Given this list of marker genes Klk5, Clasp2, Dpp4, Lamc1, Wdr72, Adamts15, Fscn1, Ets1, Sema5a, Meltf, Eng, Adamts5, Cst3, Cma1, Ddr1, Fgfr4, Clasp1, Il6, Sh3pxd2b, Exoc8, Mmp20, Plg, Noxo1, Flot1, Pbxip1, Carmil2, Hpn, Tgfb2, Kif9, Klk4, Ddr2, Pdpn (NCBI Gene Id 14726), Ctsg, Fap, Ctss, Mmp13, Lcp1, here is a description of the gene set: studied in species Mus musculus Mouse Gene Set: GOBP_EXTRACELLULAR_MATRIX_DISASSEMBLY A process that results in the breakdown of the extracellular matrix.